The following is a description of a gene set: Any process that results in a change in state or activity of a cell or an organism (in terms of movement, secretion, enzyme production, gene expression, etc.) as a result of a Thyroglobulin triiodothyronine stimulus. Mouse Gene Set: GOBP_RESPONSE_TO_THYROGLOBULIN_TRIIODOTHYRONINE studied in species Mus musculus, and this is the list of marker genes: Slc2a1, Ncoa1, Inhbb, Ncoa2, Ncor1, Glb1